The following is a description of a gene set: Human Gene Set: KONDO_COLON_CANCER_HCP_WITH_H3K27ME1 from publication Kondo Y, Shen L, Cheng AS, Ahmed S, Boumber Y, Charo C, Yamochi T, Urano T, Furukawa K, Kwabi-Addo B, Gold DL, Sekido Y, Huang TH, Issa JP (PMID 18488029) Epigenetic silencing in cancer cells is mediated by at least two distinct histone modifications, polycomb-based histone H3 lysine 27 trimethylation (H3K27triM) and H3K9 dimethylation. The relationship between DNA hypermethylation and these histone modifications is not completely understood. Using chromatin immunoprecipitation microarrays (ChIP-chip) in prostate cancer cells compared to normal prostate, we found that up to 5% of promoters (16% CpG islands and 84% non-CpG islands) were enriched with H3K27triM. These genes were silenced specifically in prostate cancer, and those CpG islands affected showed low levels of DNA methylation. Downregulation of the EZH2 histone methyltransferase restored expression of the H3K27triM target genes alone or in synergy with histone deacetylase inhibition, without affecting promoter DNA methylation, and with no effect on the expression of genes silenced by DNA hypermethylation. These data establish EZH2-mediated H3K27triM as a mechanism of tumor-suppressor gene silencing in cancer that is potentially independent of promoter DNA methylation. studied in species Homo sapiens Genes with high levels of histone H3 monomethylation mark at K27 (H3K27me1) in SW48 cells (colon cancer) by ChIP-chip assay on a 12K CpG array (CpG promoters only, HCP=high-CpG-density promoters)., and this is the list of marker genes: USP37, LINC02453, COL9A1, PCSK1N, TPP2, MAPKBP1, ZRANB3, CADM3, CSMD3, MRPL27, ACSL3, LGI2, CCNA1, MRAP2, CNOT9, DKK2, CXCR4, TPR, RNASET2, PLA2G4A, EFNA5, SRFBP1, ODR4, HLX, SIPA1, CCDC181